Given this list of marker genes Smad2, Ces1f, Gpld1, Ces1g, Nfe2l1, Ccl3, Tgfbr2, Ptch1, Pmvk, Ces1d, Ces1h, Dynapl1, Lrp8, Ces1c, Abca1, Gramd1c, Mlc1, Osbpl7, Cyp7a1, Tgfb1 (transforming growth factor, beta 1), Rorc, Insig2, Inhba, Lrp6, Dynap (dynactin associated protein), Gpr155, Inhbb, Ces1a, F7, Dag1, Gramd1b, Ces1b, Rora, Ccr5, Ces1e, Gramd1a, Tgfbr1, Smo, Insig1, here is a description of the gene set: Any process that results in a change in state or activity of a cell or an organism (in terms of movement, secretion, enzyme production, gene expression, etc.) as a result of a sterol stimulus. studied in species Mus musculus Mouse Gene Set: GOBP_RESPONSE_TO_STEROL